Given this list of marker genes PHLPP1, PTPRR, IGF2BP3, FHIP2A, CNTNAP3B, BOLL, RCHY1, ACTR2, ITM2A, MEMO1, GRAP2, LRIG3, DLG3, CTNND1, ZBTB5, DMD, GPATCH2L, RCC2, SLC6A1, OXR1, KIAA1217, SCN3A, CACNA1E, GUCY1A2, DCBLD2, ADD3, GPAM (glycerol-3-phosphate acyltransferase, mitochondrial), UBN1, RASA1, SMARCAD1, CLPX, PAIP1, SPEF2, ASIC2, WWTR1, DSG1, SPRYD7, PAG1, MPZL2, SEPTIN10, OPCML, PHACTR2, RBMXL3, NUFIP2, RBM12, CCPG1, NFATC2, NAA20, PREX2, GABRA1, SMAD4, SHROOM3, B4GALT5, CDR2L, FXN (NCBI Gene Id 2395), PRR32, ZDHHC1, TAB2, TFPI, TRIM2, HGH1, CLUAP1, INTS2, ABLIM1, ROCK1, IRF2BP2, GTF2A1 (general transcription factor IIA subunit 1), APPL1, PDE12, PLD5, GCA, CCDC121, SETD3, AVPR1A, NT5DC1, ATXN1, TRAM2, KBTBD3, SFRP1, CSRP3, CBLB, RAB27B, AFAP1L1, SLIT2, RAB39B, SGPP2, NCOA3, FSTL5, JAZF1, KDM1B, SERINC1, RAB3C, ABCB11, PTPN3, KCNB1, IRF2BPL, ZCCHC4, FBXL4, CNTN1, ATXN3 (ataxin 3), ASAP2, ABHD17B, SUMF1, MMS22L, RBPMS, LHFPL1, RBMS1, SEH1L, TMEM178A, TDP2, CDKN2AIP, SLMAP, WDR20, HDAC7, CILP2, API5, RALGPS2, PCDH15, HNRNPR, SRSF6, BBX, TMEM170B, PHLDA1, DICER1 (NCBI Gene Id 4333), RNASEH2B, ETNK1, MOSMO, PHF3, CD200R1, RSBN1, GPR82, ARHGAP26, CENPBD1P, MYT1L, ZBTB44, CDH8, KLHL20, ANKRD40, ANXA4, ARPC1B, CNTNAP2, KRAS, CDC27, TARDBP, CFL2, CTBS, RASEF, SNRPF, MARVELD1, PIP4K2A, SLC12A5, MTSS1, LYPLA1, SSPN, NCAM2, GRSF1, RABGAP1L, ST13, LDB2, ACTL6A, GSAP, RND3, FAT3, SLC4A7, CLDN8, ZNF608, ANLN, LYSMD3, PACSIN2, QKI, GPCPD1, SYT4, BAHD1, OCLN, HDAC9, TSPAN2, AAK1, ULK2, KAT2B, CACNB4, DNAJC21, TAOK1, ATP8A1, FIGN, ARHGAP5, RFPL2, CMTM6, MBNL2, ZBTB18, RUFY2 (NCBI Gene Id 55680), FLII, BRWD3, MFAP3L, CSDE1, NDST3, GABPB1, ATP7A, FYTTD1, PPP1R12A, ABHD17C, ZBTB11, FOXJ2, NRBF2, ARMC8, FRS2, SKA3, SLC25A32, SLC2A13, ARFGEF2, MTFR1, UBR2, SEMA6D, SLITRK4, PGM2L1, QSER1, TP53INP1, PRKAR1A, DNAJC12, EPHA5, RBMXL2, PDZK1, SPP1, UTP23, SLIT3 (slit guidance ligand 3), ERAP1, PDZD8, SPOPL, ZFYVE21, CNTNAP3, ARF6, OSTF1, NUP50, TBCEL, MPPED2, GPBP1L1 (GC-rich promoter binding protein 1 like 1), CPA3 (carboxypeptidase A3), ACSL4, CCDC186, ALCAM, SPRED1, STRIP2, RAVER2, TOLLIP, ZFHX3, VSTM2A, RLIM, ATF3, GPR180, RHOT1, SSBP3, KLHL11, FBXL3, SYNE2, TMEM17, ZNF704, FUBP1, NEK7, ARHGAP12, NECTIN3, RYK, ZBTB41, LIN7C, CSMD3, TP73, RBL1, SAMD9, AKTIP, MCTP1, TP63, AP4S1, TMTC3, CLCN4, SREK1, CACNA2D1, BMPR2, RRAGD (NCBI Gene Id 58528), CNOT6, GLS, SH3TC2, KRT4, WDHD1, RAPH1, CSNK1G2, SMPD3, RFPL3, DCUN1D1 (NCBI Gene Id 54165), CNTN4, FGF7, C5orf24, SLC10A7, ZNF678, ZNF22, TMTC4, RCOR1, ILF3, TFDP2 (transcription factor Dp-2), PRKCE, PJA2, SNX13 (sorting nexin 13), UBQLN1, ATP1B1, SYT14, RUNX1T1, ZSWIM6, FBXL5, ZNF630, CACUL1, TCERG1, CCDC152, CAMTA1, ZBTB20, SNX3, CORO2A, FAT4, SUGT1 (NCBI Gene Id 10910), LRRC59, GAS2, GPR158, TAF12, FGF9, HDAC2, TRAM1, SMG1, PEX7, HECW2, SLK, RASSF8, AGAP1, ZDHHC21, DPY19L4, FRAS1, MBD5, PLXDC2, BCL11A, DYNLT3, ZBTB10, USP45, RMND5A, PCNX1, OSER1, PSMG4, ACTC1, UBE2W, IL6ST, ROCK2, ADCY3, PIK3R1, SETD7, APAF1, PRP4K, THBS1, WNK3, ZNF677, INHBB, PARPBP, SSBP2, PPM1B, CCSAP, CHST1, SNX30, TRIP11, CRABP2, STAG2, ING3, NFAT5, CUL3, TFB1M, ATP2B1, UBL3, CDKN2D, HSPA4, RNF149, TIAM2, PCGF3, BACE1, REST, KIF20A, SMAD2, CADM2, SWT1, CREB1 (NCBI Gene Id 1385), RSPO2, SLC24A2, SOSTDC1, DCDC2, ABCF2, C3orf33, MAPK8, TM9SF3, UBE2D3 (NCBI Gene Id 7323), DYRK2, HIPK1, RBM48, CEP41, ATE1, FBXO38, DCP2, CHEK1, RUNDC3B, TET3, BRD1, MAPK1, PPAT, EXPH5, KIF1A, SLAIN1, MYO1C, CERT1, SAMD8, POU3F2, CELF2, PSD3, AFF2, STRN3, PITPNC1, ISCA1, LUC7L3, SUN1, COL24A1, NTNG1, TLE4, UGCG, MEGF10, TOR1AIP2, SLC35F1, ELAVL1, PDP1, TNRC6C, CDK6, CALML4, YBX3, ZNF322, POF1B, F3, RNF32, COG3, TET2, PPP1R2, UQCRC2, FBXO11 (F-box protein 11), KLHL2, PLEKHM3, APP, RAB11FIP2, HOXD8, PCDH17, TMEM101, here is a description of the gene set: Genes predicted to be targets of miRBase v22 microRNA hsa-miR-4422 in miRDB v6.0 with MirTarget v4 prediction scores > 80 (high confidence targets). Human Gene Set: MIR4422 studied in species Homo sapiens from publication Chen Y, Wang X (PMID 31504780)